The following is a description of a gene set: from publication Chen Y, Wang X (PMID 31504780) Mouse Gene Set: MIR_7671_5P Genes predicted to be targets of miRBase v22 microRNA mmu_miR_7671_5p in miRDB v6.0 with MirTarget v4 prediction scores > 80 (high confidence targets). studied in species Mus musculus, and this is the list of marker genes: Cmtm3, Katnip, Trim66, Slc43a2, Ccdc6, Plch2, Dmpk, Rassf8, Pds5b